The following is a description of a gene set: A protein complex that contains at least TOR (target of rapamycin) in complex with other signaling components. Mediates the phosphorylation and activation of downstream signaling components including PKB (AKT) or S6K. studied in species Homo sapiens Human Gene Set: GOCC_TOR_COMPLEX, and this is the list of marker genes: MTOR, PRR5 (NCBI Gene Id 86335), LARP1, SESN3, RPTOR, MLST8, AKT1S1, RICTOR, PRR5L, TTI1, MAPKAP1, SESN2